The following is a description of a gene set: Human Gene Set: GOBP_POSITIVE_REGULATION_OF_INSULIN_SECRETION studied in species Homo sapiens Any process that activates or increases the frequency, rate or extent of the regulated release of insulin., and this is the list of marker genes: ABCC8, PRKCA, SIRT3, NNAT, C1QTNF12 (NCBI Gene Id 388581), MYRIP, PFKM, TM7SF3, PRKCE, NLGN2, AACS, GPR68, GHRL, SLC2A2, SIRT6, PFKFB2, TRPM5, C2CD2L, PDX1, TUNAR, TARDBP, PLA2G6, NR1H4, GNA11, GCK, ANO1, GPLD1, JAK2, ADCY8, PRKACA, ORAI1, ISL1, ABAT, FFAR1, FFAR2, PPARD, TRPM4, UCN3, IRS2, RAPGEF4, OSBP, NKX6-1, PRKAR1A, CASR, PPP3CB, GIPR, BAIAP3, GCG, ACSL4, VSNL1, RAC1, HLA-DRB1, MLXIPL (MLX interacting protein like), CFTR, PCK2, DOC2B, SOX4, PSMD9, GLUD1, CD38, SYBU, CHRM3, TCF7L2, F2, SLC30A8, OXCT1, TRH, RBP4, CAPN10, PHPT1, CRH, F2RL2, BLK, STX4, TRPA1, GPR27, PRKN, MPC2, MCU, PRKCB, NR0B2, GPRC6A, NADK, HIF1A, GIP, GPER1, RPH3AL, ITPR1, RFX6, SERP1, BAD, PLCB1, LRRC8A, DYNLL1